Given this list of marker genes Slc4a9, Slc4a5, Slc26a5, Slc26a10, Slc39a10, Slc39a8, Slc26a4, Slc39a6, Slc26a6, Slc39a4, Slc4a1, Slc26a1, Slc26a8, Slc26a11, Slc4a2, Slc39a12, Slc26a9, Slc4a11 (NCBI Gene Id 99004), Slc26a2, Best1, Slc39a5, Slc26a7, Slc26a3, Best2, Slc4a3, Cftr, Slc39a14, Slc4a10, Slc4a7, Slc4a8 (NCBI Gene Id 59033), Slc4a4, here is a description of the gene set: Mouse Gene Set: GOMF_BICARBONATE_TRANSMEMBRANE_TRANSPORTER_ACTIVITY species: Mus musculus Enables the transfer of bicarbonate from one side of a membrane to the other. Bicarbonate is the hydrogencarbonate ion, HCO3-.